The following is a description of a gene set: Human Gene Set: GOBP_CELLULAR_RESPONSE_TO_ETHER Any process that results in a change in state or activity of a cell (in terms of movement, secretion, enzyme production, gene expression, etc.) as a result of a ether stimulus. studied in species Homo sapiens, and this is the list of marker genes: ZC3H12A, GOLPH3, LARP1 (La ribonucleoprotein 1, translational regulator), CDK4, CAV3 (caveolin 3), CD4, ZNF683, CFL1, PLCB1, AKT1